Given this list of marker genes NFATC2IP, DNAJB12, HTATSF1, RUFY1, MICU2, DCP1B, SNX2, UEVLD, YARS2, ZFYVE26, ARMT1, CSRNP2, ELOA2, DHX29, PMPCB, ZNF326, EXOSC8, OXSM, FEN1, SHQ1, MRFAP1, NIFK (NCBI Gene Id 84365), SERPINB5, DBR1, NAT1, POLR2B, UBA2, DDX52, ETFDH, TTI2, CCAR1, SART1, DCAF13, GTF3C3, LBP, N6AMT1, HECTD1, DDX19A, LRRC47, EXOSC10, RASA1, CDK11A, NPM1, AGPS, UTP11, INTS13, DPP8, TJAP1, HYLS1, C20orf202, SPDL1, MPHOSPH8, C1GALT1C1, SMARCA4, RBM8A, TRIM27, CIP2A (NCBI Gene Id 57650), RNLS, PDHX, CCDC93, MED27 (mediator complex subunit 27), PEX3, GCLM, VRK1, CELF2, YJU2B, RPAP3, AFG3L2, ERCC3, NUMB, GPKOW, ATP6V0A2, KDM2B, KAT2A, PDCL, ANAPC4, CNOT2, LANCL2, RRP15, PMS2P2, SMARCE1, QTRT2, KATNA1, UIMC1, CELA2A, ZCCHC8, RABGGTB, HNRNPD, ELP4, IFT43 (intraflagellar transport 43), MTM1 (myotubularin 1), MOAP1, KANSL2, GLCCI1, PPWD1 (peptidylprolyl isomerase domain and WD repeat containing 1), ZNF280C, FBXO33, SERBP1, SCYL3, GRK5, TRNT1, NASP, NAA35, ACAP2, FKBP3, WDR4, MAP3K7, TRAPPC11, MMP10, CRYZL1, RIOK1, HMGN5, RIOK2, NSMCE2, PTPN11, DHX40, GTPBP4, ZSCAN29, RSBN1L, UPRT, MRPS28, PPIG, MFN1, FCAMR, NDUFAF1, HNRNPDL, MCTS1, SMC6, SMG8, METTL13, FASTKD2, PSMB1, ZC3HC1, ISL1, CNDP2, TOPBP1, MRPS18A, ZNF711, C1orf131 (NCBI Gene Id 128061), UPF3B, BUD13, TMCO1, TADA1, HEXIM1, CETN2, MSTO1, GFM2, DDX46, MRPL45, ARHGEF7, SEC62, DUSP11, ARHGEF18, MON1B, EIF3J, ZBED5, ZSCAN9, PSMD1, SUPT16H, RBM28, TCERG1, EIF2B5, ABHD17C, PTRH2, NUBP1, USP48, BAG3, RSC1A1, MPHOSPH6, TRAF5, NCBP3, CPSF2, SLC4A1AP, LONP2, PPM1D, H2BC11, MED19, ZNF680, TUT4, INTS8, LLPH, USP2, INSYN2A, TTC14, ZNF776, ZNF627, PRRC1, FASTKD1, DNAJC8, PRMT3, KDM2A, TASOR2, NSDHL, SCO1, PDPK1, PIK3C3, OAT (NCBI Gene Id 4942), NUP37, USP25, here is a description of the gene set: Dendritic cells (DCs) are the sentinels of the mammalian immune system and they undergo a complex maturation process mediated by activation upon pathogen detection. Recent studies described the analysis of activated DCs by transcriptional profiling, but translation regulation was never taken in account. Therefore, the nature of the mRNAs being translated at various stages of DC activation was determined with the help of translational profiling, which is the sucrose gradient fractionation of polysomal-bound mRNAs combined to microarrays analysis. Total and polysomal-bound mRNA populations were compared in immature (0h) and LPS-stimulated (4h and 16h) human monocyte-derived DCs with the help of Affymetrix microarrays. Biostatistical analysis indicated that 296 mRNA molecules are translationally regulated during DC-activation. The most abundant biological process among the regulated mRNAs was protein biosynthesis, indicating the existence of a negative feedback loop regulating translation. Interestingly, a cluster of 17 ribosomal proteins were part of the regulated mRNAs, indicating that translation may be fine-tuned by particular components of the translational machinery. Our observations highlight the importance of translation regulation during the immune response, and may favour the identification of novel gene clusters or protein networks relevant for immunity. Our study also provides information on the possible absence of correlation between gene expression and real protein production in DCs. Genes up-regulated in comparison of polysome bound (translated) mRNA versus total mRNA 4 h after LPS (TLR4 agonist) stimulation. from publication Ceppi M, Clavarino G, Gatti E, Schmidt EK, de Gassart A, Blankenship D, Ogola G, Banchereau J, Chaussabel D, Pierre P (PMID 19943945) Human Gene Set: GSE14000_TRANSLATED_RNA_VS_MRNA_4H_LPS_DC_UP species: Homo sapiens